Given this list of marker genes ATP7A, DYRK1A, STRADA, PIGT, CENPE, CC2D2A, DPM2, PUS7, IKBKG, HDAC8, SEC24D, NALCN, ADARB1, CAMKMT, SOX5, RIT1, ZBTB7A, PAFAH1B1, RFWD3, BRPF1, AP4S1, IDUA, PHIP, TSEN54, GCK, SUFU, RELN, TRIP12, KCNJ5, PDGFRB, H4C9, TAF1, AP3B2, POLE, KCNA1, SLC13A5, SUOX, SUPT16H, B3GALT6, FREM2, SKIC2, KCNJ8, HK1, SNX10, FLNA (filamin A), SLC6A8, COX4I1, THSD1, SCN3A, TOPORS, IFT56, NEXMIF, HDAC6, UBE2A, CYP27B1, PLA2G6, PTEN, CEP63, THUMPD1, ARID2, SOS2, KDM4B, PEX10, DYNC1H1 (dynein cytoplasmic 1 heavy chain 1), ALPL, TBC1D20, POC1A, NONO, KCNK4, ATAD3A, FGFR1, CRELD1 (NCBI Gene Id 78987), UGP2, ALG9, PWAR1, SMO, GRB10, LARGE1, EFNB1, MEG3, RPL9, PHF8 (NCBI Gene Id 57793), UBAP2L, MTM1, NOTCH3, GABRB2, NCAPD2, PRDX1, ERCC5, RALA, MBTPS2, CYP2R1, KATNIP, TTC5, KCNQ1OT1, PEX3, RPL8, MMP23B, RFX7, DDX11, PDX1, FBLN5, PPP2CA (protein phosphatase 2 catalytic subunit alpha), P4HTM, TUBGCP2, DYNC2I2, CDK8, MFSD2A, SNAP25, INPPL1, PIK3R1, STIM1, ACTG2, H1-4, OFD1, MOCS2, RPS24, FKTN, COLEC11, UFC1, EZH2, LUZP1, AIFM1, IFT43, NARS2, CPLANE1, IGF2, PRIM1, SIX2, LMBRD2, SLC5A7, GOLGA2, NEPRO, LETM1, ACTL6B, PACS2, PUF60, AMER1, FBXO28, SIK1, ZNF148, D2HGDH, PIGY, WDR4, SCN2A, RPS26, TMEM231, NKX2-6, TASP1, TWIST2, SHPK (NCBI Gene Id 23729), CA2, SLC4A10, RPS10, SOX4, ZNF711, GPAA1 (NCBI Gene Id 8733), EED, TAFAZZIN, TBL2, HERC2, ITCH, AGR2, FGFR3, GABRD, PDHA1, PEX19, IL2RA, NRAS, DPH2, RPS6KA3, AMMECR1, MEGF8, PIGN, CLP1, RPL11, SYT1, CDC6, TXNDC15, ZSWIM6, OPHN1, BAZ1B, SON, CTNS, BICRA, SLC25A24, ERI1, IFT52, DPH5, MN1, SNORD115-1, POMT2, KCNN3, BCKDK, RBM10 (RNA binding motif protein 10), FREM1, WASHC4, SIN3A, UBE4B, GPC4, EIF4H, GLI3, CCN2, CDK5, EBP, FLT4, LRP5, FANCM, TSR2, ATP6V1E1, FLCN, FRA10AC1, CAMK2G, QARS1, DPP9 (dipeptidyl peptidase 9), POLR1B, GRIN1 (glutamate ionotropic receptor NMDA type subunit 1), PEX11B, ZNF335, HMGA2, RRAS2, PAK3, BUB1B, GNAO1, DIS3L2, ZNF292, MAD1L1, COL13A1, PKDCC, SCN1B, PPP2R3C, RTTN, ADA2, TRPM3, TBL1XR1, PEPD, ZBTB18, MLXIPL, CREBBP, ATR, USB1, ALX1, SETD5, VAMP1, PPARG, MAP2K1, LHX3, RYR1, AHDC1 (NCBI Gene Id 27245), FGF12, SMG8, CCBE1, ELN, ZFX, TBX1, BPNT2, SLC32A1, KDM5B, EDARADD, ZC4H2, FOS, PYCR1, CASK, DNA2, EXT2, NHEJ1, CCDC47, MAP1B, CNKSR2, COG5, RNF113A, VPS33B, KDM5C, ATIC, PAH, CACNA1B, ERF, TMEM67, SLC12A6, CLCN7 (chloride voltage-gated channel 7), ATP6AP1 (ATPase H+ transporting accessory protein 1), MAD2L2, KIAA0586, EFEMP2, NEUROD2, FIG4, SMARCB1, CAVIN1, SKIC3, ANKRD17, PPP2R5D, FANCD2, ATP6V1B2, RPL5, SCN1A, LTBP4, KPTN, MED12, PIGA, MMP2, ZNHIT3, MED27, FANCC, DTYMK, KRAS, SARS1, CHST3, BAP1 (NCBI Gene Id 8314), SLC38A3, CHD1 (NCBI Gene Id 1105), PHEX, PAK1, MMACHC (metabolism of cobalamin associated C), VPS37D, SCN8A (NCBI Gene Id 6334), ASNS, TRIP13, HBA2, HOXB1, WNT5A, EMC10, KMT5B, EXTL3, CAMSAP1 (NCBI Gene Id 55490), CCDC22, LEMD2, RPL27, APC, AARS1, P4HB, WAC, SLC26A2, PRKAR1A (NCBI Gene Id 5573), PRKACB, KCNAB2, LHX4, YWHAG, KDM6B, RAD51, SLC35C1, DVL3, KCNB1, PNPLA6, GLB1, CDK19, TFAP2B, UPF3B, COPB2, RPL15, BRAF, TBCK (TBC1 domain containing kinase), COL11A1, SMPD4, SETD2, PIGU, SVBP, CTNND1, SIX6, CDK6, PPM1B, ANTXR1, PIGG, CBFB, CDKN1C, ARCN1, SCYL2, CIT, CDKL5, WDR73, SMARCA4, SMC3, SLC18A3, TCF20, DLX4, ALDH18A1, TCOF1, DEAF1, TP63, HNRNPH1, RHOBTB2, PEX1, NIPA2, TGFB1, PEX14, NBAS, STX1A, CAMTA1 (NCBI Gene Id 23261), SMARCE1, USP9X, CRTAP, HES7, AP2M1, SPOP, GLE1, GNPNAT1, SNX14, SPECC1L, COL9A2, LFNG, KCNA2 (potassium voltage-gated channel subfamily A member 2), GMPPA, IFIH1, KCTD1, CHST14, CHD5, OCRL, ZEB2, CEP152, PPP2R1A, SNRPN, NAA20 (N-alpha-acetyltransferase 20, NatB catalytic subunit), CACNA2D1, KNL1, TCTN1, TRIM37, CEP57, CDC42BPB, TRRAP, GRIN2D, VPS35L, ATN1, CUX1, BUB3, EXOC2, KDF1, FKBP14, KYNU, SLX4, NUDT2, KCNH1, CPOX, ARID1A, FBN1, PTHLH, TIMM50, RBL2, PEX26, FLNB, TOMM7, DDX6, PTH1R, TCTN3, SEPSECS, SOX2, GNB2, FH, FGD1, INSR, MAPKAPK5, PRPS1, PEX2, KLF1, STAMBP, PHGDH, NUP133 (nucleoporin 133), CEP290, FAT4 (FAT atypical cadherin 4), RPL35, KMT2B, TAOK1, PLCB4, EIF5A, ADAM22, GABBR2, HESX1, HEPACAM, TAF13, YWHAE, SMG9, CACNA1C, ABCC9, NSD1, LARP7, CSPP1, ALG11, PDPN, CTSD, SMARCD1, PRDM13, SLC25A1, SPTA1, PREPL, B3GLCT, ALDH6A1, TCTN2, KCNJ11, BRD4, NGLY1, ACP5, DPM1, TUBGCP6, KMT2D, FANCA, B4GALT7, DMXL2, RSPRY1, CKAP2L, CTSK, DICER1, POLR1A, TOGARAM1, ATP6V1A, NFIA, STAG2 (NCBI Gene Id 10735), TTI2, AGO2, PHC1, PIK3R2, MAP2K2, MEN1, RNU12, EP300, NF1, NAA10, PCDHGC4, OTUD5 (OTU deubiquitinase 5), ETFDH, ERCC2, DYNC2I1, RNF135, CCNK, FANCI (FA complementation group I), TMEM237, NELFA, RAF1, SLC1A2, ATRX, SPEN, INPP5E, FANCE, PSAT1 (NCBI Gene Id 29968), STIL, HNRNPU, EBF3, COG4, MYCN, MYO18B, NEU1, NFIB, INTS1, DSE, KDR, TSEN34, RFC2 (NCBI Gene Id 5982), FBN2, PDE4D, RRP7A (ribosomal RNA processing 7 homolog A), NUS1, STEEP1, SRPK3, FZR1, EPB41L1, PPM1D (protein phosphatase, Mg2+/Mn2+ dependent 1D), NOVA2, EDAR, PACS1, GABRA2, RECQL4, KDM1A, NIPBL, NKX2-5, CHD3, DPH1, SLC1A3, SLC39A13, THOC6, INS (NCBI Gene Id 3630), APC2, TUBG1, B3GAT3, TMEM53, KIDINS220, ADAT3, COL1A2, VARS1, WLS, NKX6-2, PSPH, NSUN2, INTS8, ACTG1, PPFIBP1, GJB2, C1GALT1C1, WARS1 (NCBI Gene Id 7453), SLC34A3, MED13L, BUB1, TMEM107, SUMF1, POGZ, TUBGCP4, ROR2, PUM1, GJA8 (gap junction protein alpha 8), EPB41, FRMPD4, SLC25A22, PTCH1, RPS29, HBB, HUWE1, SPRED2, PTPN11, AFG2B, BGN, NXN, RNF125, NCAPG2, RBM8A, ANKRD11, IDH1, RRAGC, GPR101, FBXL4, IGBP1 (immunoglobulin binding protein 1), GPT2, PNKP, WBP11, STAT5B, RPGRIP1, DOCK6, CLIP2, HIC1, RMRP, DHDDS (dehydrodolichyl diphosphate synthase subunit), BRWD3, RAB34, GPKOW, HRAS, LGI4, ACTB, LRP2, KIF11, KIFBP, PTCH2, NOTCH2, EIF2S3, ERCC1, LBR, CASZ1, ASCC3, KAT6B, PRKD1 (protein kinase D1), LMNB1 (lamin B1), RPS28, FKBP6, CBL, POLR3A, BRCA2, ERCC4, PIGL, KANSL1, AP4M1, NLRP3, COL2A1, PLAG1, AGO1, UBA2, COL11A2, RRAS, GNE, GRM7, CTCF, DDR2, SPTBN1, RAD21, ITPR1, RSPO2, TRAPPC14, METTL5, RAB39B, ANKH, ITGA3, RPL35A, ADK, WDR35, HECTD4, CCND2, WDR37, TCIRG1, C2CD3, SP7, KDM6A, TBC1D7, CARS1, BMP2, FANCG, GALNT2, ETFA, POLD3, WDR62, FLI1, RPS15A, CELF2, CYFIP2, COASY, NUP37, AP1G1, GK, XRCC2, BRCA1, NTNG2, SETBP1, POMT1, DHCR7 (NCBI Gene Id 6589), MDH1, STAT3, ADAMTS3, EMC1, MBD5, PEX6, IL11RA, SHOC2, RIN2, SYNGAP1, MCM7, LIG4, PEX5, DYNC2H1, XRCC4, DLX3, TRPV6, ADAMTSL1, TRAPPC9, DNMT3A, DLX5, SH3PXD2B, TP53RK, SMC5, DPYD, CDH11, IPO8, PPP3CA, LRPPRC, PLCH1, RPL31, SMARCA2, NBN, TAPT1, B9D1, KCNC2, MAP3K7, MAPK1, ACAN, SLC9A7, C12orf57, CAMK2B, LIFR, FRAS1, PURA (NCBI Gene Id 5813), DNAJC30, PLAAT3, ZNF462, TBX2, DDX59, AP1S2, CITED2, SMAD2, RBBP8, RAB3GAP1, STXBP1, SATB1, PRKDC (protein kinase, DNA-activated, catalytic subunit), GABRA5, RPL26, SLC12A2, FAM149B1, TCF4, INTS11, IFT80, TCF12, PRKCZ, STT3A, AFF4, SIK3, CPLX1, DLK1, RAB23, MYO9A, NCAPD3, TRPS1, SZT2, KREMEN1, MTOR (NCBI Gene Id 2476, mechanistic target of rapamycin kinase), VDR, AP4B1, CEP295, PRKAR1B, DCHS1, PROP1, UBA5, KIF14, GTF2IRD1, PRMT7, FAM50A, TET3, TFAP2A, GDF11, KAT6A, LRP1 (NCBI Gene Id 4035), NARS1, IRX5, RTL1, NUP188, SOX11, POLR1C, TWIST1, ALX3, NTRK2, TMEM270, HBA1, PPP1CB, DEPDC5, AXIN1, FOCAD, CAV1, TRAK1, SMOC1, PEX13, HCN1, PLK4, GATAD2B, GTF2I, WWOX, WNK3, KATNB1, PDE6D, SLC3A1, MGP, ZBTB20, BCORL1, AIP, WDR26, RNU4-2, TSPEAR, MED25, BMP1, TENT5A, HSPG2, CDH2, MSX2, FMR1, LIMK1, MOCS1, SLC25A46, TRAPPC10, ODC1, HECW2, FARSB, DIAPH1, SLC16A2, TBCD, ERMARD, CHRNA7, RPS20, ASPM, NDE1, MED12L, CHD8, POU1F1, BUD23, PWRN1, RAI1, CACNA1A, PPP1R21, KMT2A, SRC, GYPC, FOXC1, PDCD6IP, NPAP1, PIK3CD (phosphatidylinositol-4,5-bisphosphate 3-kinase catalytic subunit delta), ETFB, GJA1, SOX9, MYH3, ALX4, DOCK7, RPS19, SETD1A, NUP107, SASS6, GNPTAB, ESAM, OSGEP (NCBI Gene Id 55644), CWC27, MARS2, HS6ST2, EMG1, DLL3, LEMD3, SATB2, RNPC3, FANCB, SIM1, DHCR24, ORAI1, UBR7, KIAA0753, DPYSL5, IFT140, ATP1A3, EEF1A2 (eukaryotic translation elongation factor 1 alpha 2), B9D2, BRIP1, ACOX1, DRG1, SCUBE3, PIGS, CTBP1, FGFR2 (NCBI Gene Id 2263), MAPRE2, DALRD3, IFT57, KMT2E, ARX, PITX2, KIF26A, SCN4A, BMPR1A, TAF6, CNTNAP2, FLII, HOXD13, MEF2C, GPC3, VPS53, VPS33A, AGRN, SRCAP, WNT4, CHAT, SYT2, TECPR2, THOC2, PEX12, KCNJ6, GATA1 (NCBI Gene Id 2623), SLC2A1, MAGEL2, PMM2, PIGP, ADSL, EDA, PIK3C2A, IFT122 (intraflagellar transport 122), SOS1, UBE2T, FZD2, ZNF526, FGFRL1, PALB2, GATA4, NANS, SMAD3, FANCF, GABRG2, ASXL3 (NCBI Gene Id 80816), EXOSC2 (NCBI Gene Id 23404), SEC23A, MID1, KCNJ1, GH1, NIPA1, CCDC8, RERE, OCLN, H3-3A, MTX2, GNS, CNOT3, CRPPA, TRIM8, SLC25A12, LYN, DVL1, CDC42 (NCBI Gene Id 998), IARS2, ZFPM2, MESP2, DNM1 (NCBI Gene Id 1759), ROBO1, RAB18, FBXO31 (F-box protein 31), PIGQ, MBTPS1, RASA2, SYNJ1, YY1, HEATR3, AGPAT2, CCNQ, TONSL, MITF, MAN2C1, TBC1D24, MAB21L1, CPT2, ZNF699, CAPRIN1, ABCC8, NPR2, AP1S1, FOXP1, CLCN3, ASXL1, INTU, VAC14, PIK3CA, ARID1B, DDB1, CDK5RAP2, SH2B1, CUL4B, PTDSS1, BMP4, RARS2, ZPR1, CUL7, STAT6, ADNP, IFT81, LRP4, GLI2, AP4E1, HIVEP2, COG7, KCNJ2, H4C5, ATP6V0A2, NSD2, COL27A1, SOX6, CLTC, RPGRIP1L, SNORD116-1, RUNX2, GET4, KCNK9, CHD6 (NCBI Gene Id 84181), DHX30, MAN2B1, GON7 (NCBI Gene Id 84520), IGF1, ATP6AP2, LZTR1, SPTB, RNU4ATAC, ANKLE2, CRIPT, SUZ12, TBX4, NFKBIA, SERPINH1, POU4F1, LMX1B, CHD2, CSGALNACT1, POLR2A, ORC1, FBXO11, VPS13B, WBP4, MPDZ, TMEM216, TMCO1 (transmembrane and coiled-coil domains 1), PGAP1, RAP1GDS1, RPS7, DPF2, HNRNPK, FUCA1, JAG1, PLAA, FILIP1, ABL1 (ABL proto-oncogene 1, non-receptor tyrosine kinase), RALGAPA1, MKRN3, TRPV4, VIPAS39, RPL10, NECAP1, SMC1A, POR, HERC1, PYCR2, TTC7A, PRUNE1, TCEAL1, IL6ST, AKT3, MYOD1, GJA5, GHR, DENND5A, MKS1, SMARCC2, FRMD4A, FOXG1, ZIC2, CNOT1, TSEN15, IER3IP1, DYNC1I2, PEX16, BSCL2, LAGE3, GATA5, EPG5, KDM5A, ASH1L, COL18A1, PCNT, GTF2IRD2, TRMT10A, GPC6 (glypican 6), PIGK, PPP1R13L (protein phosphatase 1 regulatory subunit 13 like), SOST, TMLHE, EXOSC5, TNPO2, WDR19, RNF13, SLC6A1, TRAPPC4, NPHP3, GDF1, MRAS, RPS27, EXOSC1, H19, PRDM16, NFIX (nuclear factor I X), KCNQ1, ZDHHC9, FANCL, MTSS2, KIF7, GATA6, RPS17, HDAC4, LARS1, TRIO, NSRP1, EDA2R, UNC45A, SPRTN, RIPPLY2, GJB6, CEP135, GMNN, KNSTRN, IQSEC2, SC5D, FUT8, UNC80, ARNT2, TMEM147, ACER3, PIGB, ZIC1, PPP1R15B, POLR1D, FAM111A, OBSL1, RLIM, HSD17B4, SLC25A19, TBCE, JARID2, PARS2 (NCBI Gene Id 91517), CTU2, ATP1A2, TBX15, NRCAM, COL1A1, GNPAT, HYOU1, AMPD2, RAD51C, NCF1, H3-3B, COX7B, TOE1, TSEN2, RPL18, ERCC6, HS2ST1, MAB21L2, TRIP11, TRAF6, NAB2, MAF, SALL4, CENPJ, RYR3, COX5A, MAN1B1, CDH1, EFEMP1, RAB3GAP2, PAM16, GTPBP2, METTL27, FKRP, WASHC5, SCNM1, PCGF2, SKI, ASXL2, MCPH1, MEIS2, MADD, NCAPH, PEX7, CCDC88A, here is a description of the gene set: An anomaly of the forehead. species: Homo sapiens Human Gene Set: HP_ABNORMAL_FOREHEAD_MORPHOLOGY Abnormal forehead morphology